The following is a description of a gene set: species: Mus musculus Mouse Gene Set: GOBP_NEGATIVE_REGULATION_OF_IRON_ION_TRANSMEMBRANE_TRANSPORT Any process that stops, prevents, or reduces the frequency, rate or extent of the directed movement of iron ions from one side of a membrane to the other by means of some agent such as a transporter or pore., and this is the list of marker genes: Atp7a, Hamp2, Iscu, Nos1, Hamp